The following is a description of a gene set: Human Gene Set: GSE16697_CD4_TCELL_VS_TFH_CD4_TCELL_DN Genes down-regulated in CD4 T cells versus follicular helper CD4 T cells. species: Homo sapiens Analysis of in vivo antigen-specific (LCMV-specific, SMARTA TCR transgenic) follicular helper CD4 T cells (CXCR5high),versus non-follicular helper CD4 T cells (CXCR5low), eight days after viral infection. A paper including data analysis of these experiments has been accepted for publication (Robert J. Johnston et al. Bcl6 and Blimp-1 are reciprocal and antagonistic regulators of follicular helper CD4 T cell differentiation). from publication Johnston RJ, Poholek AC, DiToro D, Yusuf I, Eto D, Barnett B, Dent AL, Craft J, Crotty S (PMID 19608860), and this is the list of marker genes: GALNT7, SMPDL3A, RAB3D, FKBP5, INPP1, LGALS3BP (NCBI Gene Id 3959), HDHD5, FLT3LG, CCND2, ADAMTS10, TNFRSF18, CACNA2D4, DNAJC6, RCBTB2, HGSNAT, ZDHHC15, CYRIA, DENND2D, PDE6G, ASXL1, GRAMD4, LPIN1, ITGB2, RAB4A, MEIS3, LFNG, DCTN6, ARL15, ZAP70, RAP2B, LDLRAP1, IGSF23, PSTK, PPIC, CAST, ZYX, ITM2A, ITGB7, RGS11, LCK, GPR83 (NCBI Gene Id 95200), ICOS, SMPD5, MYL6, EPAS1, FNTB, ITGB3, GALNT2, HCST, DPYSL2, FASLG, PDHA1, L1CAM, RAB23, ZBTB7B, ARHGAP29, ZNRF1, CCS, FAM78A, USP28, SPO11, EMB, MTHFD2, DGKA, GPR34, MGST2, RINL, SLCO3A1, PRKCZ, IL18R1, ARHGAP31, TRIB2, ZNF579, CALCRL, SLC39A11, PCED1B, ERAP1, RAB37, BAG3, ST8SIA6, IGF2R, TNFSF8 (TNF superfamily member 8), IGFLR1, SMC4, PIP4P2, DAP, ARHGEF4, TMIE, MEX3B, SMOX, AVEN, FGFBP3, ZNF623, ZBTB45, IMPDH1 (NCBI Gene Id 6105), RNF19A, NHERF1, PEA15, ABCB9, RCOR3, PELI1, PDK1, PELI2, ATP8B4, CYB5A, OXR1, LRRC75B, RHBDL3, METTL9, GTF2I, IL6R, RUNDC3B (RUN domain containing 3B), SIGIRR (NCBI Gene Id 59307), STXBP5, LY75, AFP, PGLYRP2, RAB8B, FAS, INPP5B, PPM1H, LIPA, EVA1B, SNX4, DNAJC3, RNASEL, FRMD8, MIB1, SDCBP2, LIME1, DIPK2A, SPATA6, FAM234A, CERS6, DDX60, NLK, HADHB, FLOT2, STX1A, SLC35B3, BDH1, SEPTIN9, SLC48A1, KCNMB4, PEAK1, BCL9L, OTULINL, CCR8, SSBP3, HSD11B1, EOMES, LHX3, ITGA6, ADGRL1, TECPR1, SLC20A1, RBPJ, CLN3, PATJ, BICDL1, F2RL1, RNF125, LAD1, SLC25A23, DCUN1D3, SSBP4, RFLNB, ZNF512B, EMC9 (NCBI Gene Id 95655), FOCAD, GPSM2, TNFSF10, VIPR1, PDE3B (phosphodiesterase 3B), NDRG3, GOLM1, MACROD1, IL6ST, VPS26B (NCBI Gene Id 112936), KBTBD11 (kelch repeat and BTB domain containing 11), SLC35G1, APP, SFMBT2, PAQR7, CRMP1, CKB, P2RX7, NUP153, CCND3, CISH, CMAS, SH2D2A, DEF6, AREG, SNAP47, ARRB2, TNFRSF25, FRRS1 (ferric chelate reductase 1), DGKZ, EXOC6B